Given this list of marker genes LMNA, FGFR1, SHPK, FGFR2, PLAGL1, ZMPSTE24, MTX2, ANTXR1, MITF, COL11A1, ALG9, HYMAI, POLA1, LEMD2, PDGFRB, CACNA1C, INPPL1, HERC1, NFIX, SKI, MAF (NCBI Gene Id 4094), TWIST1, FBN1, DBR1, ADAMTS10, SIN3A, P4HB, FLNB, KCNJ6, PLOD3, PTCH1, ESCO2, SETBP1, HNRNPK, SERPINH1, GNPTAB, here is a description of the gene set: Shallow orbits studied in species Homo sapiens Human Gene Set: HP_SHALLOW_ORBITS Reduced depth of the orbits associated with prominent-appearing ocular globes.